Given this list of marker genes Nsfl1c, Gins2, Polb, Camta2, Gm10230, Esrrb, Zwilch, Tspyl4, Srf, Rfwd3, Gon4l, Htatsf1, A1cf, Hmgxb4, Csnk2a1, Plk5, Rad50, BC005624, Tcf7l1, Hmgb1, Pbx4, Apc, Tbx6, Capn2, Gins4, Smarcd2, H3c7, Zfp202, H2ab2, Rad21l, Tcf3, Vps72, Tardbp, H3f5, Wdr4, Arpc1a, Spo11, Baz2a, Cdk2ap1rt (cyclin dependent kinase 2 associated protein 1 retrotransposed), Polr1b, Suv39h2, Setdb2, Rif1, Faap100, Nkx3-1, Pias3, Rbmx (RNA binding motif protein, X chromosome), H1f5 (NCBI Gene Id 56702), H2al1j, H2ac8, Cenpq, Chmp1a, Hnrnpa2b1, H1f0, Septin6, Spin4, Nr1h4, 4930402K13Rik, Brms1, Polq, Khdc3, Phox2b, Ncapg2, Chmp7, Gm20911, Rhno1, Pax6, Orc2, Alyreffm9, Rrs1, Tada2a, Spout1, Esco1, Ubap2l, Ahdc1, Cyren, Nr6a1, Fmr1, 3830403N18Rik, Kntc1, Mbd5, Pds5b, Terf2, Jade1, Gm10257, Ercc6, Tgm2, Tcf23, Gm28576, Nr3c1, Aurkc, H2bc3, Phf12, Taf1, Selenoo, Llph-ps1, H2ac23, Actr2, Rtf2, Nde1, Cbx7, Mus81, Cenpa, Ppp2r1a, Arhgap33os, Gm2030, Foxd3, Chd8, Akirin2, Esr1, Hsf4, Dppa3, Zeb2, H2ac12, Ppp2r5a (NCBI Gene Id 226849), Bicral, Ago3, Pold1, Wdr76, Gar1, Fen1, H2al1m, Sun1, Rad51, Ruvbl2, Rad17, Mllt3, Gm28870, Spi1, H2ac24, Chaserr, Ddx23, Paxx, Ascl5, Ncor2, Zbtb4, Esrrg, Ercc4, Cdx2, Pbrm1, Syce1, Acd, Eid3, Rest, Kif4, Mcm4, Rnf169, Gm21760, Ezh2, Zfp768, Hmgn2, Sox10, Arid1b, Bub1, Brix1, H1f1, Zfr, Gm21865, Mcm7, Zbtb7a, Hmga1b, Anapc7, Nmnat1, Fam47e, Chmp5, Gatad2a, Tex264, Smarcd1, Actr3, Pml, Hsf1, Chmp3, Ang4, Phf6, Suz12, Jarid2, Supt3, Spata22, Top2b, H2al2a, Fbxo11, Tex12, Chd6, Hdac5, Llph, Nsd2, Cbx2, Sgo1, Kmt5c, Sycp2l (NCBI Gene Id 637277), Alyref, Ska2, Ccdc137, Nacc2, Tinf2, Pole4, Bcl7b, Cbx8, Smad1, Cited2, Ppp1cc (NCBI Gene Id 627816), Setd2, Redic1, Gm4297, Srpk2, Nr5a2, Tox4, Atxn7l3, Cip2a, Brd8, Aunip, H4c8, Sall1, H3c4, Rara, Chd3, Utp4, Jade3, Rad51b, Prm3, Rfc5, Gm29866, Hmbox1, Sirt1, H2al2b, Ints7, Slf1, Spdl1, Alyreffm3, Exd2, Slfn9, Zscan4c, Tspyl2, Rhox5, Rpa3, Arglu1, Suv39h1, Zfp385a, Cebpb, Parpbp, Nsd1, Cenpp, Gm6121, Thoc6, Akap8l, Taf6l, Usp22, Add3, Terb2, Rpa2, Ss18, Gnl3, Obi1, Cdc5lrt1, Thoc7, Tbx3, Macroh2a2, Fance, Set, Cdc5lrt8, Prr14, Fam111a, Rassf2 (NCBI Gene Id 99374), Chmp4b, Dpf1, Oip5, Chmp4c, Arpc5, Kif2b, Htra2, Tal1, Gpatch11, H2ac22, Nek2, Mta3, H4c18, Sap130, Smarca4, Pawr, Prkaa1, Supt7l, Chtf18, H3f4, Xlr4c, Dhx36, Smarcad1, Baz2b, Trim66, Ppard, Rnf20, Spidr, Rfx3, Hnf4a, Gm20890, Alyref2, Thoc3, Trim37, Eef1akmt3, Champ1, Ipo4, Irf4, 2810004N23Rik, Asf1b, Gm5935, Fancc, Trappc12, Men1, Srpk1, Arpc3, Nsl1 (NCBI Gene Id 98359), Tuba1a, Phf2, Rsf1, Cops9, Krr1, Kat7, Oard1, Zscan4f, Dtl (NCBI Gene Id 76843), Kdm4a, Polr2b, Phox2a, Gm20843, Tubg1, Sgo2b, H2al1b, Orc1, Atp1b4, Kdm1b, Mycl, Hnrnpdl, Ncoa1, Chrac1, Kifap3, Tspyl1, Trps1, Gm6421, Pot1a, Ncapd3, Tbx20, Fancg, Samd1, Dynlt3, Plrg1 (pleiotropic regulator 1), Ccnd2, Pias4, Prdm9, Hat1, Rec114, Plk4, Ttk, H2al1n, Atf2, H2ac13, Hmgb3, Cdc5lrt6, Slf2, Ubr2 (ubiquitin protein ligase E3 component n-recognin 2), Spin1, Kat2a, Slx1b, Zmiz1, Slc5a8, H3f3b, Airn, Mcm10, Knstrn, Rnf2, Mlh3, Mbtd1, Psen1, Rad51ap1, Cdc5lrt5, Tnks, Fbl, Yy2, Sinhcaf, Actl6a, H2az2, H3c10, H4c1, Rarg, Alyreffm5, Mlxipl, Pot1b, Ubap2, Alkbh1, Ctcfl, Zmynd8, Psmc3ip, Ankrd2, Cenps, Alyreffm11, Zfa-ps, Atad5, Xlr3c, Prpf4b, Ppp4r2, Cntd1, Hus1b, Mef2a, Aurka, Kif22, Xrcc5, H3f3a-ps1, Cenpm, Zfp42, Numa1, Dntt, Shprh, H2ac7, Plk1, Xrcc2, Ube2b, Pitx3, H3c11 (NCBI Gene Id 319153), Alyreffm4, Dr1, Top1mt, Fignl1, Ddx27 (DEAD box helicase 27), Recql4, Brd1, Tasor, Seh1l, Setd7, Klf2, Pcgf5, Top3a, Mybbp1a, Ankrd31, Pcgf2, H3f3a-ps2 (NCBI Gene Id 15080), Tcp1, Wdr5, Ccdc86, Esr2, Chd7, Ddb1, Smad2, Rsl1d1, Dctn2, Emx1, Ncor1, Smarcc2 (SWI/SNF related, matrix associated, actin dependent regulator of chromatin, subfamily c, member 2, NCBI Gene Id 68094), H2al1o, Ogt, Flywch1, Ten1, Dnmt3l, Tex14, Parp2, Terf2ip, Nup43, Msh6, Usp7 (ubiquitin specific peptidase 7), Phf1, Utp6 (NCBI Gene Id 216987), Plk3, Tipin, Syce3, Ubr5, Exosc5, Rela, H1f8, Gata4, Clasp2, Gm20820, Noc2l, Tbx22, Luzp1, Rnf212, Poll, Ncaph2, Map3k7, Bcas3, Uvrag, Rtel1, Eme1, Fbxo28, Zbtb32, Gm21117, Parg (NCBI Gene Id 26430), Nuf2, Nono, Mlh1, H2bl1, H2al1a, Adprs, Pcgf3, Rpa1, Brd3, Cbx5, Topbp1, Dffb, Hmgb2, Ang5, H2ac11, Ska1, Rad9a, Prmt5, Chmp1b2, Blm, Nbn, Ark2n, Aurkb, Arrb1, Msh4, Llph-ps2, Kansl2, Gm5934, Gatad2b, Anp32e, Shld2, Gins1, Foxc1, Bub3, Cenpi, Nfatc1, Brd9, Il33, Tbr1, Pkhd1, Ing4, Pias2, Zfp330, Tnp1, Hmgn1, Morc2b, Fank1, Nr0b2, Wrnip1, Gm2012, Csnk1a1, Cenpe, Ar, Hdac8, Nsmce4a, Smg6, Fer (NCBI Gene Id 80679), Dsn1, Msl3, Msh2, Rad51c, Trim33, Actg1, Setd5, Fbxw7, Exosc10 (NCBI Gene Id 50912), Prpf19, Ddx11, Stat6, Brpf1, Cenpo, Chd5, Nanog, Atr, Ehmt1, Zbtb10, Kdm4d, Tbx19, Hormad2, Top3b, Nfe2l2, Kdm5d, Ccnb1ip1, Hif3a, Tert, Sec13, Csnk2b, Kmt2e, Actbl2, Rbmxl1, Ncl, Akirin1, Samhd1, Dna2, Ahctf1, Stk38, Rad9b, Ring1, Cenpw, Trp53tg5, Smarcb1 (NCBI Gene Id 20587), Zzz3, H2bw2, Rbbp7, Rpf2, Hmg20b, Mad2l1, Rcc1, H4c12, Csnk2a2, Isl1 (ISL1 transcription factor, LIM/homeodomain), Rrp1b, Xlr, Nsd3 (nuclear receptor binding SET domain protein 3), H2ac19, Rnf138, Brca2, Terf1, H3f3c, Hes1, Fiz1, Sirt2, Ndc80, Gm20817, Bend2 (NCBI Gene Id 108168453), Ubqln4, Pbxip1, Phf20l1, Dync1i1, Hic1, Lrif1, Prim1, Firrm, H1f4, Fancf, Xrcc6, Xlr3b, Sgo2a, Nap1l1, Tcf7, Vcp, H4c17, Dmrtc2, Ufl1, Gm28510, Wdr43, Incenp, Telo2, H2az1, Phc2, Ppp2r5c, Cdkn2a, Lig3, Nup160, Taf6, Supt20, Smad3, Myocd, Xlr5a (X-linked lymphocyte-regulated 5A), Nup85, Rnf168, Snai2, Nhlh2, Bcas2, Hnrnpl, Macroh2a1, Mnx1, Setx, Skic3, Kdm2a (NCBI Gene Id 71431), H2ac1, Vdr, Cdyl, Mphosph8, Sfr1, Gata5, Gm29276, H2bc14, Exosc4, Shld3, Bend3, Cenpk, Ppp1r10, Cul5, Rnf8, H3f3a, Park7, Sin3a, Brms1l, Atxn7, Mcm5, Lemd2, Kif18a, Kdm2b, Polr1a, Ssrp1, H3c1, Rcc2, Pole3, Ints3, Dnttip1, Ctcf, L3mbtl1, Ss18l1, Ncapd2, Rfc4, Cenpb, Ing5, Recql5, Pou4f1, Wdhd1, Chd1, Stag2, Tbx1, H2aj, Zranb3, Stag1, Repin1, Dnmt3a, Polk, Nop53, Ddb2, Ep300, Pum3, Smarcd3, Etv3, Dmc1, Spindoc, Gm10488, Ncoa3, Rrp8, Cenpx, Smcr8, Tex11, Kdm3a, Eed, Dyrk1b (dual-specificity tyrosine phosphorylation regulated kinase 1b), Lrwd1, Uhrf2, Parp1, Alyreffm10, Septin7 (NCBI Gene Id 235072), Tbx4, Tbx10 (T-box 10), Smarca5, Pole, Nabp1, Pold2, H2ac21, Chmp2a, Tbx5, Vrk1, Maged1, Rcor2, Tcf7l2, Atm, Arpc4, Nsmce3, Cdc5lrt9, Nscme3l, Brd8dc, Bmyc, Trrap, Smarca1, Rangap1, Rmi1, Ftsj3, Ppp4r3b, Ppp1ca, Twnk, Morc3, Ino80e, Pold4 (NCBI Gene Id 69745), Pogz, Faap20, Xrcc3, Lrpprc, Smc6, Dctn3, Mei4, Brd4, H2ac20, Shld1, Tonsl, H2bc21, Dnmt1, Nusap1, Spag5, Fancb, Rbbp4, 1700028K03Rik, Sox18 (NCBI Gene Id 98938), H3c14, Pes1, Ncaph, Irf7, Satb2, Dnttip2, Zmynd11, Sycp3, Exosc9, Exosc8, Slx4, Ang, Mga, Gm1140, Dvl3, Glyr1, Polh, Npm2, Ankrd17, Smarce1, Srcap, Nrip1, Hdac1, Mta2, Mms22l, Sf3b3, Bicra, Ddx21, Irf1, Orc6 (origin recognition complex, subunit 6), Dync1li1, H2bc26, Chd1l, Banf2, Pink1, Rnf40, P3h4, Pphln1, Mis12, Trp73, Tada2b, Tcf12 (NCBI Gene Id 319985), Chmp2b, Actr5, Kdm5a, Orc3, Trip13, Mdc1, Usp3, Zscan4d, H2al1e, Cdc20, Taf2, Cgas, Hmga2, Stat3, Srsf2, Runx3, Ezh1, Mbd6 (NCBI Gene Id 28087), Actr8, Cbx6, Smchd1, Pgr, H2bc18, Ino80b, Prkdc, H2ap, Hspa2, Bcl7c, Slxl1, Nabp2, Nipbl, Ang2, Nhej1 (NCBI Gene Id 75570), Cenpf, Cbx3, Fancl, Kmt5a, Suds3, Cdc5l, Hnrnpab, Aldoa, Parp9, Pif1, Gm21627, Ddx6, Taf10, Rccd1, Prr19 (proline rich 19), Cdk2ap2, Ncapg, Arid2, Thap7, Tspyl5, Hormad1, Kat14, Hotair, Dlx5, Phf10, Hells, Daxx, Hnf1a, Smc3, Cdca2, Ctnnb1, Brip1, Gm21996, Creb3l2, Cdca8, Hus1, Zfp827, Klf4 (Kruppel-like transcription factor 4 (gut)), Kdm4b, H1f10, Crebbp, Bcl7a, Nr4a2, Nup107, Xlr4a, Cdt1, Id2 (NCBI Gene Id 97802), Sf3b1, Hoxa13, H2al3, Mphosph10, Mexis, Brd7 (bromodomain containing 7), Dynll1, Egr1, Tspyl3, Ell, Nr3c2, Nap1l2, Spocd1, Slfn8, Gm28919, Setd3, Ing1, Mixl1, Bap1, Pds5a, Hlcs, Actb, Dync1li2, Nat8, Xpo1, Lef1, Trp63, Zfp410, Usp11 (ubiquitin specific peptidase 11), Bod1l, Tmpo, Fh1, Uchl5, E2f4, H2ac4, Relb, Ercc6l, Parp3, Atf7, Zmiz2, Donson, Nelfe, Orc4, Ndel1, Irf3, Psen2, H2al1k, Gm20824, Runx1, Helb, H2bc9, Sirt7, Cbx1, Kdm5b, Aptx, Uvssa (UV stimulated scaffold protein A), Slx, Ing3, Gata3, Uimc1, Max, Setd1b, Paxip1, Hp1bp3, Kansl1, Inip, Nucks1, Xlr4b, Wrap53, Bysl, Pwp1, Hand2, Gm1993 (NCBI Gene Id 100038977), Tnks2, Runx2, Morc2a, Hjurp, Baz1a, Mis18bp1, Dpf3, Kdm5c, Etv4, Prdx1, H1f7 (NCBI Gene Id 70069), Rb1, Atf6b, Peli1, Taf4, Chmp1b, Supt16, Lhx3, Bnc2, Grwd1, Sphk2, Muc1, Gins3, Etaa1, Pou1f1, Pinx1, H3c2, Aim2, Taf9b, 4930447C04Rik, Cenpu, H2bc1, Cdk2ap1, Ppp1cb, Snai1, Mxd1 (NCBI Gene Id 17119), Jun, Syce2, Kansl3, Syce1l, Hnrnpk, Xlr5c, Yeats4, Polr2a, Chaf1b, Sgf29, 0610010K14Rik, Surf6, Ckap5, Syn1, Bcl11b, Yy1, Itgb3bp, Med1, Fancm, Mcm3, Nol6, Ino80c, Alyreffm6, Tada1, Kat5, Xist, Ube2a, Tnp2 (transition protein 2), Tfpt, Nup133, Bcl11a, Sin3b, Setmar, Smarca2 (SWI/SNF related, matrix associated, actin dependent regulator of chromatin, subfamily a, member 2), Tbx2, Chek1, Gm28102, Vrtn, Radx, Ttn (NCBI Gene Id 99250), Nol7, Thoc5, Xlr3a, Ctr9, Ice1, Iho1, Nol8, Chek2, Fancd2, Cops5, Arid1a, Gm29554, H2ac15 (H2A clustered histone 15), Rnf138rt1, Wapl, Morf4l1, Scml2, Dctn5, Phf14, Dapk3, Zfp207, Tcf4, Rad1, Meiob, Actr6, Taf5l, Jak2, Hmces, Cfdp1, Ngdn, Ebf4, Bmi1, Asf1a, Ppp2cb, Rsph1, Uxt, Phc1, Usp51, Rbm31y, Kdm4c, Eloa, H4c6, Emg1 (NCBI Gene Id 14791), Qser1, Thoc2l, Tbx15, Alyreffm1, Kat8 (K(lysine) acetyltransferase 8), Hmgn5, Usf1, Epc1 (enhancer of polycomb homolog 1), Nsmce1, Chmp6, Msh5, Cenpv, Cdc5lrt7, Taf7, Hdac2, Zbtb46, Brd2, Hand2os1 (Hand2, opposite strand 1), H2bc22, Thoc1, H3c8, Spc25, Timeless, Pold3 (polymerase (DNA-directed), delta 3, accessory subunit), Wbp2 (WW domain binding protein 2), Fbxw11, Sugt1, Gabpa, Msl1, Mrgbp, Sycp1, Hrob, Haspin, Gm21095, Ddx18, Was, Thoc2, Ppp2ca, Prim2, Spc24, Nifk, Sap30, Smad4, Ska3, Stag3, Ldb1, Gm14525, Dhx9, Myo1c, H2al1f, Sycp2, Hmgn3, Epc2, Banf1, Zfp57, Nap1l4, Meaf6, Neil3, Iffo1, Mael, Xrcc4, Creb3l1, Nup98, Epop, Primpol, Dnmt3b, Plcb1, Hcfc1, Sumo1, Casz1, Rxra, Gm20870, Creb1, 1700013H16Rik, Dctn1, Dffa, Nr1h3, Zc3h8, Ell3, H2bc27, Rnf212b, Dpf2, Ing2, Mbd3, Nufip1, Clasp1, Ercc5, Rbbp6, Zw10, Fam47c, H3c6, Mecp2, H2ac6, Taf12 (NCBI Gene Id 66464), Pramel13, Mcm8, Mcm6, Rbl2, Pias1, Ist1, Rad51d, Rrp1, Zfp618 (zinc finger protein 618), Esrra, Smarcal1, Kdm3b, Anapc16, Ankrd11, Mbd2, Ino80 (INO80 complex subunit), Ppp1r7, H1f2, Adnp, Igfbp3, Zfp692, Hr, H4c11, Clock, Baz1b, Trnp1, Pmf1, Jade2, Hnrnpu, Terb1, Akap8, Taf9, Pcna, Arpc2, Rbbp8, Bptf, Pola1, Swi5, Padi2, Wrn, H4c9, H4c4, Lig4, Enc1, Ilk, Nsmce2, H4c2, Top1, Ehmt2, 4930480E11Rik, Ppp4c (NCBI Gene Id 56420), Ebna1bp2, Nr4a1, Kat6b, Smc5, Gtf2b, Zfp277, Cenpt, Mad1l1, Cdca5, H2ab3, Psip1, Cdk2, Birc5, Hmbs, Myc, Eomes, Morf4l2, Chd2, Gm5169, Hmgb4, Ice2 (interactor of little elongation complex ELL subunit 2), Pak1, Rfc1, Hira, Mtbp, Cpsf6, Cenph, Rec8, Cdc45, Hsf5, Ccar2, Arid4a, Msl3l2, Setdb1, H1f9, Sf3b5, E2f1, Brme1 (break repair meiotic recombinase recruitment factor 1), Nudcd2, Setd1a, H3c13, Basp1, Sirt6, Myod1, Bop1, Septin2, Tet3, Bahd1, Chd4, Aff4, Cecr2, H1f3, Prdm10, Kat6a, H4c3, Hif1a, Nfkb1, Brpf3, Cenpl, Faap24, Taf5, Mad2l2, Smc1b, Fanca, Xlr5b, Zfx, Ddi2, H2ax, Xrcc1, Carm1, Tet1, Nup37, H2ac25, Brca1, Mcm9, Ppp1r12a, Ppp1ccb, Dctn6, Gm5168, Pnkp, Gm21858, Uba1 (ubiquitin-like modifier activating enzyme 1), Cdc5lrt10, Stat1, Klf1, T, Rbl1, Rbm19, Eme2, Mbd1, Arid4b (NCBI Gene Id 94246), Mta1, Loxl2, Ctc1, Mki67, Tet2, Trp53, Exosc3, Tbp, Trp53bp1, Tnks1bp1, Nap1l3, Dmap1, Kdm8, Rfc3, Znhit1, Mis18a, Hmga1, Phf20, Zfp276, Actl6b, Wdr82, Ercc1, Nlrp2, Birc2, Aplf, H3c15, Jmjd1c, Dclre1b, Kdm1a, Sfpq, Rad18, Pole2, Ppargc1a, Pafah1b1, Ang6, Rfc2, Pou5f1, Uhrf1, Ik, Gm21064, Usp37 (ubiquitin specific peptidase 37), Recql, Xpa, Zbtb48, Cdc5lrt4, Knl1, Nfatc2, Orc5, Klhdc3, Brdt, Gm21294, Smarcc1, Nasp, Get4, Dctn4, Nr1d1, Dek, Gm773, Msl2 (NCBI Gene Id 77853), Alyreffm7, Trim24, Acte1, Sdr16c5, Nfat5, Plk2, H2ab1, Top2a, Mcrs1, Eny2, Yeats2, Ino80d, Bms1, Traip, Bub1b, Smc2, Zc3h4, Neil1, Sprtn, Hsf2bp, Tpr, Ccnb1-ps, Sp1, Shoc1, Ccnb1, Prm1, Skic8, Prm2, Trim28, Pelp1, Kmt5b, Cenpc1, Hdac3 (NCBI Gene Id 15183), Mcm2, Wdr70, Mbip, Ruvbl1, Zwint, Hnrnpd, Zfp830, Kat2b, Tada3, Ep400, Xpc, H3c3, Cdk4, Mbd4, Esco2, Nsmf, Gm28961, Sap30l, E2f6, Kif2c, H1f6, Kash5, Upf1, Majin, Chaf1a, Mau2, Hpf1, Ash1l, H4c16, Smc1a, Crx, Pou4f2, Rbm34, Nedd4, Rad21, Gm7958, Zcwpw1, Snw1, Kansl1l, Bcl6, Alyreffm8, Hdac4, Sox2, Bud31, Gm20736, Mre11a, Cenpn, Fkbp6, Ash2l, Meikin, Zfp143, Irag2, Myt1l, Rmi2, H2bc12, Stn1 (STN1, CST complex subunit), Pola2, Top6bl, Helq (NCBI Gene Id 338528), Satb1, Dscc1, Tep1 (NCBI Gene Id 546226), Nfrkb, Calcoco1, Atrx, Bod1 (biorientation of chromosomes in cell division 1), Mcm3ap, Lmna, Ikzf1, Chtf8, Fbh1, Pin4, Tbx18, Tfip11, Sun2, H2ac10, Mtcl1, Trex1, Smc4, Ran, Spdya, Sall4, H4c14, Foxh1, Tbx21, here is a description of the gene set: Mouse Gene Set: GOCC_CHROMOSOME studied in species Mus musculus A structure composed of a very long molecule of DNA and associated proteins (e.g. histones) that carries hereditary information.